Given this list of marker genes RXRA, KDM1A, APOC2, MIR26B (microRNA 26b), ABCG1, MIR613, APOE, ABCG5, ABCG8 (NCBI Gene Id 64241), RXRB (NCBI Gene Id 6257), AGO3, NCOR2, TNRC6C, MIR26A2, ABCA1, APOD, TNRC6A, GPS2, PLTP, TBL1XR1, APOC4, AGO4, KDM1B, HDAC3, NCOR1, MIR33A, APOC1, MIR26A1, NR1H2 (nuclear receptor subfamily 1 group H member 2), TNRC6B, KDM4A (lysine demethylase 4A), MOV10, EEPD1, AGO1, NR1H3, MIR33B, MIR144, ARL4C, NCOA1, TBL1X, EP300, KDM3A, AGO2, CETP, here is a description of the gene set: The liver X receptors (LXRs), LXRα (NR1H3) and LXRβ (NR1H2), are nuclear receptors that are activated by endogenous oxysterols, oxidized derivatives of cholesterol (Janowski BA et al. 1996). When cellular oxysterols accumulate as a result of increasing concentrations of cholesterol, NR1H2,3 induce the transcription of genes that protect cells from cholesterol overload (Zhao C & Dahlman‑Wright K 2010; Ma Z et al. 2017). In peripheral cells such as macrophages, NR1H2 and NR1H3 increase cholesterol efflux by inducing expression of ATP-binding cassette subfamily A type 1 (ABCA1), ABCG1, and apolipoprotein APOE (Jakobsson T et al. 2009; Laffitte BA et al. 2001; Mak PA et al. 2002). In the intestine, LXR agonists decrease cholesterol absorption through induction of ABCA1, ABCG5, and ABCG8 (Repa JJ et al. 2000; Back SS et al. 2013). Cholesterol removal from non-hepatic peripheral cells, such as lipid-laden macrophages, and its delivery back to the liver for catabolism and excretion are processes collectively known as reverse cholesterol transport (RCT) (Francis GA 2010; Rosenson RS et al. 2012). 2009; Back SS et al. 2013; Mak PA et al. 2002). Reactome Pathway: NR1H3 & NR1H2 regulate gene expression linked to cholesterol transport and efflux studied in species Homo sapiens part of: NR1H2 and NR1H3-mediated signaling